The following is a description of a gene set: The purinoreceptors are divided into inotropic (P2XR) and metabotropic (P2YR) subtypes whose ligands are the nucleotides ATP and UDP respectively. The binding of these nucleotides to their receptors on macrophages have been associated with the activation of the inflammasome leading to the subsequent activation of interleukin 1 beta (IL1β) and TNF-α (Cekic et al. 2016 & Figueiredo et al. 2016). The liberation of ATP comes from tissues facing stressful stimuli such as a tissue injury or microorganism infection, amongst others. As a regulatory mechanism, certain enzymes can reduce ATP to Adenosine and a nucleoside can stimulate signalling pathways leading to the synthesis of anti-inflammatory cytokines. <br> <br>The activation of the receptor P2RX7 was shown to lead to the activation of killing mechanisms or cell death programs, ending up in the elimination of microbes such as Leishmania amazonensis, Mycobacterium tuberculosis, Chlamydia psittaci, and Toxoplasma gondii (Coutinho-Silva et al. 2012 & Idzko, 2014). part of: Cell recruitment (pro-inflammatory response) species: Homo sapiens Reactome Pathway: Purinergic signaling in leishmaniasis infection, and this is the list of marker genes: ENTPD5, IL18, P2RX4, HMOX1, hly, SUGT1, IL1B, NFKB1, P2RX7, CTSG, MEFV, APP, ENTPD1, NT5E, IL1A, C3, HSP90AB1, TXNIP, TXN, NLRP3, GSDMD, CASP1, PYCARD, PSTPIP1, C3AR1, NFKB2, RELA